Given this list of marker genes SIPA1L1, AURKAIP1, TXNDC9, FBXO31, WDR59, MTFR1L, NAE1, NOP14, RPL4, SEPTIN10, RXRB, MARCHF7, TAB3, FMC1-LUC7L2, ERICH6-AS1, RBM4B, GDI2, CD320, CCT8, PPCDC, NCAPG, FAM200B, HMOX2, ANKRD54, PSMD14, PPOX, CUL3, SIRT5, MED22, CLIC1, MATR3, HASPIN, ANKFY1, WDR44, CCNC, NAA60, IFT74-AS1, TIMM17A, ANG, GGH, ATL1, TMCO1, IKZF5, SLC25A11, IFT74, COX7B, KPNA2, MAP1LC3B, PIBF1, PHB1, TBC1D17, UPF3B, STRIP1, GRK6, DIS3, DNAJC27, B4GAT1, EIF1AD, ZNF559 (NCBI Gene Id 84527), TRAPPC2, ATP5F1C, MED16, ATG4B, CCDC47, TRIM41, ERGIC2, HUWE1, SMG5, UMAD1, ASMTL, ATP5MC1 (ATP synthase membrane subunit c locus 1), GOLGA8B, SUCLG1, RFC5, LINC01116, ARPC4, RNU4ATAC, MRPS18C, SMARCC1, CDC26, ERCC6L2-AS1, NAPEPLD, CD2AP, SEC63, USP47, SNORA21, RPS2, AHCTF1, SYPL1, C1S, PDPR2P, COPB2, CILK1, ATPSCKMT, ZFC3H1, SHQ1, TMEM11-DT, LIMD1-AS1, PSMC5, COPB2-DT, CNP, MSH5, PTK7, ACO2 (aconitase 2), FBN1, LIN37, MDH1B, GLCE, PRMT5, IKBKB, C2orf42, EMD, ENSG00000271860, LINC02236, PCCA, PCMTD1-DT, SNORD2, CFAP418, CACYBP, LSM8, CENPT, PCDH1, MAU2, WDR6, RPS19, RNU6ATAC, PPP1R12A, MRE11, GSAP, CARMIL1, PRR4, FAM135A, SKA3, S100A3, NPRL3, GRB2, MPC2, ATP5PB, MSH5-SAPCD1, TTC23, MCCC2, DGUOK, MIR3912, RC3H2, ZNF850 (zinc finger protein 850), FKBPL, SLC44A1, MAP3K7, RAB33B, TSPYL1, TRAPPC3, NPR3, FAM111A-DT, SUGP1, ADNP, THAP1, SDK2, TMEM107, MTRF1L, HELQ, C1RL, ANK3, EPHB3, SEMA3B, RNU12 (RNA, U12 small nuclear), DDHD2, NOL9, F8, RAB1B, VTRNA1-1, RPS15A, MBTPS1-DT, TMEM11, KIAA1191, NCOA7, ZMYM3, BRF1, PRTG, NDUFA11, C1orf74, RPL7A, TRIM7-AS2, COQ2, SRSF10, MKKS, SSR4, EIF4A3, TMEM79, RPL10A, SNHG16, ZNF346, PPP4R3B, RAB37, ADAMTS7P4 (ADAMTS7 pseudogene 4), ERH, PRDX1, EHD2, SNX18, LUC7L2, BTBD10, PSMD5, WDR46, LRSAM1, PSMB3, SMARCC2, SRRT, FHL1P1, ENTPD1-AS1, HMGN5, PRPF40B, ZFP91, H3C9P, GRK4, SGSM2, CDC20, SUPT5H, SLC12A2-DT, PHAF1, SPDL1, CIP2A, COL1A1, STYXL1 (NCBI Gene Id 51657, serine/threonine/tyrosine interacting like 1), RSL24D1 (ribosomal L24 domain containing 1), IMP3, ABCC10, CYB5D1, RAB11A, RPA3 (NCBI Gene Id 6119), PANK2-AS1, THAP7-AS1, ZW10, MRTFB, RFC3, PTGR2, DENR, ETV5, BZW1, DFFA, HSBP1, TIA1, LASP1, ILF2, HJV, CDH13-AS2, BCAS3, TMCO1-AS1, QRICH1, DSE, LINC01962, PARP2, TTC14, CCNG1, UBE2D3, EDRF1, INTS13, JPH2, ABI1, EFHC1, LINC02800, PLEKHG2, ENSG00000266313, PRH1, TUSC3, BCAS4, ZNF559-ZNF177, HDAC10, MOB1A, LINC02168, MICOS10-DT, MRPL57, NFYC, GORASP2, ZFP30, RPL27A, LTV1, CAND1, SMNDC1, SPATA33, DMXL1-DT, COQ9, SMC4, RPPH1, TMEM44-AS1, EFHD1, AP5Z1, ZCCHC14, NAA35, ZNF136, MIR4521, MOB1B, SMC5, CCNJ, TCF4, TARDBP, ARF3, ITGA3, BCAR3, AFF4-DT, DRG1, PRPF4, ACADSB, PHF5A (PHD finger protein 5A), NUP37, MIR100HG, ZNF697, PNN, USP39, CDC123 (NCBI Gene Id 8872), PFKFB2, SLC25A4, STXBP4, SLC12A2, TUBGCP5, COX11, SEC62, NCL, YY1, CHURC1, PIGW (NCBI Gene Id 284098), ATN1, POLDIP3 (NCBI Gene Id 84271), EXOC8, CDC20-DT, ZNF217, RNASE11, BTN2A3P, CLP1, DNAJC27-AS1, RPL17, MCRIP2, VMP1, IREB2, CBR3-AS1, NPTN, GID8 (GID complex subunit 8 homolog), TCEANC2, GAS8, MICOS10-NBL1, NMRAL1, FBN1-DT, NKTR, TADA3, HSPA6, PUF60, STIM2, ATF7-NPFF, LINC02768, SIL1, ZSCAN25, THAP2, SMG7, VTRNA1-3, SRP19, ITGAE (NCBI Gene Id 3682), RPL17-C18orf32, INKA2, LRP3, POLG-DT, GRWD1, RNU6-9, ZKSCAN2 (NCBI Gene Id 342357), SMARCA5, EHD1, RPL23, TERC, TCF3, BANF1, GPR146, LINC02574 (NCBI Gene Id 111216282), ZNF302, AKT1S1, DCTN2, ABHD18, METTL26, SRSF5, MYO19, TRIM37, PHF12, SLC35B4, GPN3, RPL26, GOLGB1, CHUK, CETN2, AKAP1, DPYSL3, CDK12, HERPUD2, MIR3678, HSPH1, PABPC4, IPP, RBM26-AS1, NSDHL, ZNF790, SETD5, CCNJL, RFK, GSE1, PURA, LINC02572, CORO7, CCT5, MYNN, METTL16, SMIM27, SPRTN, AP4E1 (adaptor related protein complex 4 subunit epsilon 1), TFPT, TSR1, PPP4R3B-DT, IFT80, AGBL3, YOD1, PTPN4, CATSPERG, HERC1, FASTKD2, C6orf89, DBR1, RNF38, GPATCH3, TLDC2 (TBC/LysM-associated domain containing 2), NDUFS7, B4GAT1-DT, AKAP11 (A-kinase anchoring protein 11), PRPF31, FBXL5, POLR2B, PFDN6, S100A2, MICU2, RNA5SP456, RAMAC, ACBD4, SNRNP70, RHEX, LTA4H, PPM1G, MRPS7, STAG3L4, FDPS, CENPB, RPS3A, SLC15A4, PARPBP, ATAD3A, OSMR, MAPK14, DZIP3, MFSD8, TAS1R1, BROX, RNF167, AKAP1-DT, ANKRD13C, H4C8, PANK2, RCC1, CHUK-DT, RBM26, SLC25A26, UBE2D3-AS1, DCAF6, CENPC, OXCT1, SHPRH, NCOA4, MAGOHB, ETFA, KIRREL3, CHURC1-FNTB, SNORA78, RBM15, CCDC77, KBTBD6-DT, TEAD1, C1RL-AS1, WDR27, RAB27A, DARS1, AIDA (NCBI Gene Id 92615), DLX1, MIR4470, DIDO1, JOSD2, SLC39A9, INTS9, DNAJB4, DCAF16, SMG7-AS1, RELCH, SACM1L, NKAP, ANKRD49, GPR19, WARS2, ADGRL1-AS1, RICTOR, ANKRD13C-DT, BANP, NEK2-DT, VDAC3, LIN7C, MAD2L1, SF1-DT, COMTD1, PIGN, LINC02453, HDAC6, GATAD1, MGRN1, ALOXE3, ICMT-DT, FUBP1, PXMP2, LPXN, MGME1, PCMTD1, MFSD4A, PTPN1, ETF1, FMC1, CUL5, SLC14A2, THADA, PSMD14-DT, ATG4A, SCAMP5, SRCAP, POLR1C, DHX37, RNASE4, HOMER2, DNER, ASPH, ARRDC3, IDH3G, IFRD1, CIAPIN1, SPTY2D1, PTRH2, LINC01749, KIN, ICMT, DDX42, SLX4IP, PRDX4, NOP16, TIPIN, CYB561D1, GGNBP2, NKRF, GPBP1, SNORD58B, TLCD1, RNPC3, HERPUD2-AS1, MMS22L, COASY, ATF7, NANP, TMEM18, SEPTIN7-DT, XRRA1, SEPTIN7, PIPOX (NCBI Gene Id 51268), FAM76A, CREBZF, ASH2L, RRAGA, TGOLN2, PAXBP1, HNRNPH3, ATF2, LINC01426, PLXDC1, TSPAN17, DPP9, RAB33B-AS1, DNTTIP2 (NCBI Gene Id 30836), MRPL39, ARPC4-TTLL3, ZNF185, CST3, ANKRD36B, PPP1R2, MBTPS1, ZNF839, EFNA3, POLR3E, LRRC28, MDH2, TROAP, SH3BGRL, TMEM245, KBTBD6, SAXO1, TEX9, EIF4A2, TAF1C, WDR73, MAP4K5, UPF3A, ZNF317, POLG, GGA3, ZFP91-CNTF, ASXL1, TAOK1, CCNT1, NAA38, CHIC2, LYRM7, USP54, HSPA4, FAM111A, MAP2K2, SF1, SOWAHC, RBPJ (NCBI Gene Id 51580), ZZZ3, F12, PMS2P4, EIF5, FUNDC2, CDC5L, MRPS14, FGFR1OP2, RNU1-8P, SSBP4, POP7 (NCBI Gene Id 82671), TYW1, CFAP70, SPC25, DHX8, JAKMIP2-AS1, RPS11, PIH1D1, POLR2E, RPL12, PGBD4, MLF2, NSUN3, HCG14, CST9, RBM17, GMPPA, ZNF337-AS1, XPC, SENP7, RPS6, EPCIP-AS1, XPNPEP1, CLPX, SPCS2, PPEF1, MED1, ATF4, DHFR2, YY1-DT, BCLAF1, NUDT2, WARS2-AS1, SLC9A7, VPS51, NANS, HOXA13 (homeobox A13), MYO1C, CSDE1, CD2AP-DT, MAK16, CEP350, THUMPD3-AS1, C6orf120, GOLM2, WDR77, TBC1D5, TFRC, ZNF414, RPS15, UIMC1, GRIK4, NRBF2, SPAG16, TMEM209, LSM14A (LSM14A mRNA processing body assembly factor), RBM39, CHAF1A, NOL11, PPP1R10, UBE2D2, RPS9, CLPTM1, ZNF286B, GCLC, CCND1 (NCBI Gene Id 893), YIPF3, TMEM59, OFD1, CIAO1, SPAG16-DT, BCAP29, CLASP1, AHSA2P, LAMP1, SEC22C, CNPY2, ZNF345, SNHG3, SLC39A7, ITPR3, FTCD, COX4I1, TAS2R14, RPS28, HMBOX1, NDUFA7, ASF1B, NUDT5, RNY3, RNPC3-DT, NCAPG2, SPOCK1, TMEM127, VTRNA1-2, CHMP1A, FTSJ3, NPM1, DNAJA3, ERICH6, ZNF420, DDX19A-DT, MRPS18B, POLR2H, EDRF1-DT, IFT46, TASOR2, SMDT1, MIR933, PLOD2, FSIP1, AHCYL1, SNHG9, PDRG1, AGL, DMXL1, SLU7, UHRF2, THAP7, HEG1, AGA, SSR1, C5orf24, ENSG00000267260, MAD2L1-DT, ERCC6L2, TTC14-DT, BDNF-AS, MGAT5B, GIPC2, RIC8B, MICOS10, EMC7 (NCBI Gene Id 56851), MAD1L1, ASNSD1, UBR3, FAM216A, SNX5, DDX19A, SYN3, ZWILCH, ADAT1, ADISSP, RPS7, POLE, WASHC4, ATP1A1-AS1, CDC25B, PRMT5-DT, here is a description of the gene set: studied in species Homo sapiens from publication Yevshin I, Sharipov R, Kolmykov S, Kondrakhin Y, Kolpakov F (PMID 30445619) Genes containing one or more binding sites for (DYRK1A) in their promoter regions (TSS -1000,+100 bp) as identified by GTRD version 20.06 ChIP-seq harmonization. Human Gene Set: DYRK1A_TARGET_GENES